The following is a description of a gene set: studied in species Mus musculus Any process that modulates the frequency, rate or extent of modification of synaptic structure. Mouse Gene Set: GOBP_REGULATION_OF_MODIFICATION_OF_SYNAPTIC_STRUCTURE, and this is the list of marker genes: Gripap1, Chmp2b, Egln1, Cln3, Amot, Cap2, Epha4, Strn4, Dip2a, Kif5b, Rhob, Pdxp (NCBI Gene Id 72032), Gsk3b, Rapgef2, Kalrn, Cyfip1, Nf1, Zdhhc17, Cttnbp2, Abl1, Prmt8, Myh10, Camkv, Ptk2, Tiam1, Marcks, Itsn1, Myo5b, Cdc42, Rhoa, Baiap2